The following is a description of a gene set: studied in species Mus musculus from publication Cui A, Huang T, Li S, Ma A, Pérez JL, Sander C, Keskin DB, Wu CJ, Fraenkel E, Hacohen N (PMID 38057668) Mouse Gene Set: CUI_T_CELL_CD8_IL17B_RESPONSE_UP Cytokines mediate cell-cell communication in the immune system and represent important therapeutic targets. A myriad of studies have highlighted their central role in immune function, yet we lack a global view of the cellular responses of each immune cell type to each cytokine. To address this gap, the authors created the Immune Dictionary, a compendium of single-cell transcriptomic profiles of more than 17 immune cell types in response to each of 86 cytokines (>1,400 cytokine-cell type combinations) in mouse lymph nodes in vivo. A cytokine-centric view of the dictionary revealed that most cytokines induce highly cell-type-specific responses. For example, the inflammatory cytokine interleukin-1β induces distinct gene programmes in almost every cell type. A cell-type-centric view of the dictionary identified more than 66 cytokine-driven cellular polarization states across immune cell types, including previously uncharacterized states such as an interleukin-18-induced polyfunctional natural killer cell state. Genes positively differentially expressed in cell type: CD8+ T cell upon treatment with cytokine: IL-17B in mouse lymph nodes in vivo., and this is the list of marker genes: Stat1, Rtp4, Ifi27l2a, H2-T23, Isg15, Ifit3